The following is a description of a gene set: species: Homo sapiens Human Gene Set: GOBP_REGULATION_OF_DNA_STRAND_ELONGATION Any process that modulates the rate, frequency or extent of DNA strand elongation. DNA strand elongation is the DNA metabolic process in which an existing DNA strand is extended by activities including the addition of nucleotides to the 3' end of the strand., and this is the list of marker genes: TFPT, MCRS1, POT1, NFRKB, INO80C, INO80, ACTL6A, YY1, UCHL5, NUCKS1, INO80B, ACTR8, INO80D (NCBI Gene Id 54891), RUVBL2, INO80E, RUVBL1, ACTR5